Given this list of marker genes COMMD9, RMND5B, BOD1L1, TMEM138, CNPPD1, DHX29, ANKRD10 (NCBI Gene Id 55608), METTL17, MMAB, ABHD16A, TBC1D10B, CRAMP1, TADA2B, DENND4A, MORF4L1, GFM2, TBC1D14, PSME3, DDX47, RPL7L1 (ribosomal protein L7 like 1), SNX33, S100PBP, BABAM1, NF2, DHX37, ING1, TTC17, COQ10A, TRAPPC14, TINF2, TBC1D22B, ZNF274, FBXL20, DBNL, PRDM4, ANAPC5, NSUN5P1, POLR2M, BAHD1, SIN3A, TEX261, here is a description of the gene set: species: Homo sapiens Neighborhood of TINF2 TERF1 (TRF1)-interacting nuclear factor 2 in the GCM expression compendium Neighborhood of TINF2 Human Gene Set: GCM_TINF2